The following is a description of a gene set: studied in species Mus musculus The process that mediates signaling interactions between one cell and another cell by transfer of current between their adjacent cytoplasms via intercellular protein channels. Mouse Gene Set: GOBP_CELL_COMMUNICATION_BY_ELECTRICAL_COUPLING, and this is the list of marker genes: Camk2d, Pde4d, Sri, Gjc1, Gja6, Gja5, Casq2, Hrc, Tbx5, Cav1, Slc8a1, Ank3, Gjb6, Gjb2, Gjc2, Kcna1, Gja1, Dbn1, Cabp1, Irx3 (NCBI Gene Id 16373), Gjd3